Given this list of marker genes IGF1, PARP2, ARX, IGF2, CACNA2D2, MIR204, FGF8, ZFPM2, PROX1, TBX20, ACACB, HEY2, MIR17HG, WT1, MIR222, RAG2, BASP1, PIM1, TBX5, HLX, SASH3, GLI1, BMP10, MIR19A, YBX3, TBX2, ERBB4, MIR19B1 (NCBI Gene Id 406980), AKT1, BMPR1A, CCNB1, NOTCH1, GATA6, FGFR1, SERP1, SMO, MEF2C, FGF2, MIR590, MIR548C, EDN1, WNT2, IL7 (NCBI Gene Id 3574), RBPJ, FGFR2, MAPK14, MIR509-1, MIR208A, MIR199A1, AKAP6, YAP1, NRG1, FGF9, CDK1, TGFBR3, here is a description of the gene set: Human Gene Set: GOBP_POSITIVE_REGULATION_OF_ORGAN_GROWTH studied in species Homo sapiens Any process that activates or increases the frequency, rate or extent of growth of an organ of an organism.